The following is a description of a gene set: Human Gene Set: REACTOME_HIV_INFECTION HIV Infection species: Homo sapiens, and this is the list of marker genes: AP1S3, AP1S2, CDK9, PSMA5, GTF2A2 (general transcription factor IIA subunit 2), GTF2H5 (general transcription factor IIH subunit 5), NUP214, CHMP4A, PSMD14, GTF2B, GTF2A1, GTF2F1, TAF7, NCBP1, RAC1, CTDP1 (NCBI Gene Id 9150), RAN, NUP160, PSMC3, DOCK2, XRCC5, HCK, NUP133, RANGAP1, NEDD4L, CHMP4C, ELOB, POLR2B, POLR2I, POLR2A, LCK, TAF1L, GTF2F2 (general transcription factor IIF subunit 2), AP2S1, NUP98, CHMP3, PSMB3, VPS37C, PSMB4, PACS1, UBC, ERCC3, TAF9B, NUP93, TAF9, CCNT1 (cyclin T1), VPS28, CD4, PSMA3, PSMC1, TAF5, NELFB, UBAP1, CHMP2A, BANF1, PSMB1, CXCR4, LIG1, AP1M2, NELFA (NCBI Gene Id 7469), RCC1, VPS37B, NUP58, POLR2J, CHMP2B, NELFCD, AP2A2, VPS4A (vacuolar protein sorting 4 homolog A), BTRC, PSMD8, TAF2, AP2B1, GTF2E2, HMGA1, TPR, AP2M1, NUP35, TSG101, PSMA1, PSMC2 (proteasome 26S subunit, ATPase 2), VPS37D, NUP107, PSMC4, ATP6V1H, SLC25A6, XRCC4, RBX1 (ring-box 1), CHMP7, PSMC5, CCNK, NUP155, AP2A1, SLC25A5, SEM1, POLR2C, RPS27A, PSMA2, PSIP1 (NCBI Gene Id 93428), GTF2H3, XRCC6, NUP37, NMT2, TCEA1, TAF6, POM121, VTA1, CD28, NCBP2, NUP188, NDC1, RANBP2, PSMC6, MVB12B, PAK2, POLR2H, TAF10, AP1S1, TAF11, PSMD1, NUP62, ADRM1, KPNB1, POLR2E, SUPT5H, NUP88, KPNA1, AP1B1, APOBEC3G (apolipoprotein B mRNA editing enzyme catalytic subunit 3G), CHMP6, PSMB5, CDK7, CUL5 (cullin 5), POLR2D, PSMD11, XPO1, NUP42, NMT1, TBP, PSMD3, ELOA, RANBP1, GTF2H1, PSMB7, NUP210, ARF1, POLR2G, MNAT1, HLA-A, CD8B, MVB12A, NUP85, NUP205, PSMD2, GTF2H2, TAF12, UBB, TAF3, PDCD6IP, CD247, NUP50, VPS4B, SEC13, PSMD7, POLR2K, ELOA2, ELMO1, NUP43, AAAS, AP1G1, PSMD6, CHMP4B, GTF2E1, SUPT16H (NCBI Gene Id 6831), NELFE, POLR2F, NUP153, NPM1, PSMB2, TAF4B, PSMA7, GTF2H4, AP1M1, FYN, PSMA4, TAF1, UBA52, RNGTT, FURIN, POM121C, RAE1, ELOC, PSMD12, RNMT, SUPT4H1, NUP54, PSMB6, LIG4, TAF15, SEH1L, B2M, TAF13, PSMA6, SSRP1 (NCBI Gene Id 6749), ELL, SKP1, FEN1, TAF4, CCNT2, CCNH, PPIA, SLC25A4, ERCC2, CHMP5, POLR2L, PSMD13 (proteasome 26S subunit, non-ATPase 13), CCR5, TAF7L, VPS37A